The following is a description of a gene set: studied in species Mus musculus Mouse Gene Set: GOBP_RESPONSE_TO_AMYLOID_BETA Any process that results in a change in state or activity of a cell or an organism (in terms of movement, secretion, enzyme production, gene expression, etc.) as a result of a amyloid-beta stimulus., and this is the list of marker genes: Lgmn (legumain), Cdk5, Fpr-rs4 (formyl peptide receptor, related sequence 4), Syk, Tlr4, Chrna7, Ephb2, Fpr-rs7, Foxo3, Gsk3b, Grm5, Ramp3, Gja1, Bace1, Tlr6, Fpr2, Calcr, Icam1, Mmp9, Abcc1, Vcam1, Psen1, Ager, Fcgr2b, App, Prnp, Itga4, Fpr-rs3, Lrp1, Atp1a3, Cacnb1, Fpr-rs6 (NCBI Gene Id 321020), Cacna2d1, Igf1, Epha4, Cd36, Fyn, Cacna1a, Mmp2, Adrb2, Ngfr, Parp1, Tnf, Trem2, Igf1r, Bcl2l2, Cacna1b, Snx6, Sirt1